Given this list of marker genes BNIP3, TP53INP1, ATG5, LAPTM5, CDKN1B (NCBI Gene Id 1027), DAPK1, TREM2, CDKN2D, SH3GLB1 (NCBI Gene Id 51100), here is a description of the gene set: A form of programmed cell death that is accompanied by the formation of autophagosomes. Autophagic cell death is characterized by lack of chromatin condensation and massive vacuolization of the cytoplasm, with little or no uptake by phagocytic cells. species: Homo sapiens Human Gene Set: GOBP_AUTOPHAGIC_CELL_DEATH